The following is a description of a gene set: studied in species Mus musculus Mouse Gene Set: REACTOME_P75_NTR_RECEPTOR_MEDIATED_SIGNALLING p75 NTR receptor-mediated signalling, and this is the list of marker genes: Aph1a, Ngef, Plekhg5, Ubb, Ywhae, Fgd4, Arhgef25, Arhgef12, Arhgef7, Arhgef38 (Rho guanine nucleotide exchange factor 38), Sqstm1, Mcf2l, Fgd2, Uba52rt (ubiquitin A-52 residue ribosomal protein fusion product 1, retrotransposed), Ngfr, Ubc, Rela, Rac1, Myd88, Arhgdia, Lingo1, Abr, Arhgef1, Arhgef16, Aph1b, Mag, Arhgef5, Prkci, Rps27a, Irak1, Arhgef11, Arhgef33, Trio, Arhgef39, Nfkb1, Arhgef17 (Rho guanine nucleotide exchange factor 17), Plekhg2, Arhgef10l, Arhgef9, Tiam2, Fgd3, Itgb3bp, Sos2, Ect2, Vav3, Psenen, Ngf, Arhgef15, Arhgef2, Casp3, Psen1, Bcl2l11, Mapk8, Adam17, Prex1, Rhoa, Arhgef18, Arhgef3, Akap13 (A kinase anchor protein 13), Net1, Obscn, Traf6, Vav2, Bad, Arhgef26, Rasgrf2, Mcf2, Uba52, Itsn1, Sos1, Omg, Ncstn, Casp2, Arhgef10, Arhgef6, Gna13, Kalrn, Fgd1, Nfkbia, Ikbkb, Vav1, Arhgef19, Arhgef37, Ripk2, Rtn4, Bex3